The following is a description of a gene set: from publication Chen Y, Wang X (PMID 31504780) Mouse Gene Set: MIR_7071_3P species: Mus musculus Genes predicted to be targets of miRBase v22 microRNA mmu_miR_7071_3p in miRDB v6.0 with MirTarget v4 prediction scores > 80 (high confidence targets)., and this is the list of marker genes: Clrn2, Rbms3, Tmprss15 (NCBI Gene Id 353032), Trabd, 9430015G10Rik, Vwce, Mpz, Lce1g